The following is a description of a gene set: Human Gene Set: GOMF_DOLICHYL_PHOSPHATE_MANNOSE_PROTEIN_MANNOSYLTRANSFERASE_ACTIVITY studied in species Homo sapiens Catalysis of the reaction: dolichyl phosphate D-mannose + protein = dolichyl phosphate + O-D-mannosylprotein., and this is the list of marker genes: TMTC3, TMTC4, TMTC1, POMT2, TMEM260, POMT1, DPM1, TMTC2